The following is a description of a gene set: In transcription-coupled nucleotide excision repair (TC-NER), similar to global genome nucleotide excision repair (GG-NER), the oligonucleotide that contains the lesion is excised from the open bubble structure via dual incision of the affected DNA strand. 5' incision by the ERCC1:ERCC4 (ERCC1:XPF) endonuclease precedes 3' incision by ERCC5 (XPG) endonuclease. In order for the TC-NER pre-incision complex to assemble and the endonucleases to incise the damaged DNA strand, the RNA polymerase II (RNA Pol II) complex has to backtrack - reverse translocate from the damage site. Although the mechanistic details of this process are largely unknown in mammals, it may involve ERCC6/ERCC8-mediated chromatin remodelling/ubiquitination events, the DNA helicase activity of the TFIIH complex and TCEA1 (TFIIS)-stimulated cleavage of the 3' protruding end of nascent mRNA by RNA Pol II. part of: Transcription-Coupled Nucleotide Excision Repair (TC-NER) studied in species Homo sapiens Reactome Pathway: Dual incision in TC-NER, and this is the list of marker genes: GTF2H5, ISY1, RFC1, POLR2F, UBA52, PPIE, GTF2H1, RPA3, POLD2, CDK7, RPA2, POLR2J, ZNF830, POLE4, POLR2D, POLR2L, POLK, POLE2, POLR2K, POLR2A, POLR2I, CUL4B, POLR2B, MNAT1 (MNAT1 component of CDK activating kinase), POLR2G, PRPF19, POLE3, XPA, ERCC6, PCNA, CCNH, AQR, RFC4, POLE, DDB1, ERCC3, RPA1, RFC3, ERCC8, GTF2H4, XAB2, ERCC5 (ERCC excision repair 5, endonuclease), RFC5, UBB, UBC, TCEA1, CUL4A, GTF2H3, POLR2E, POLR2H, POLD3, RBX1, RFC2, UVSSA, POLD4, ERCC4, GTF2H2, POLR2C, ERCC1, USP7, ERCC2, POLD1, RPS27A